Given this list of marker genes SDC3, IDUA, UXS1, HS6ST3, HS3ST5, CSPG5, XYLT2, HS6ST2, B3GAT1, GPC6, GLB1, NDST2, HPSE2, SDC2, HGSNAT, HS3ST2, CSPG4 (chondroitin sulfate proteoglycan 4), NDST4, VCAN, BCAN, HSPG2, B3GAT3, HS3ST6, HS6ST1, SDC1 (syndecan 1), NCAN, HS3ST3A1, NDST1, GLCE, IDS, HS3ST1, EXT2, GLB1L, HS3ST3B1, GLB1L2, GUSB, NAGLU, GPC5, B3GALT6, BGN, XYLT1, AGRN (agrin), B4GALT7, HS2ST1, GPC3, SLC35D2, HS3ST4, GLB1L3, SGSH, GPC2, B3GAT2, EXT1, SDC4, GPC4, NDST3, GPC1, DCN, HPSE, here is a description of the gene set: Human Gene Set: REACTOME_HEPARAN_SULFATE_HEPARIN_HS_GAG_METABOLISM studied in species Homo sapiens Heparan sulfate/heparin (HS-GAG) metabolism